The following is a description of a gene set: Complete absence of the dynein arms of respiratory motile cilia, that is, absence of the inner and the outer dynein arms, which normally are situated inside and outside of the peripheral microtubules of motile cilia. This feature is usually appreciated by electron microscopy. Human Gene Set: HP_ABSENT_INNER_AND_OUTER_DYNEIN_ARMS Absent inner and outer dynein arms studied in species Homo sapiens, and this is the list of marker genes: TTC12, DNAAF3, DNAAF11, ZMYND10, CFAP300